The following is a description of a gene set: Mouse Gene Set: GOBP_REGULATION_OF_MITOTIC_CELL_CYCLE Any process that modulates the rate or extent of progress through the mitotic cell cycle. species: Mus musculus, and this is the list of marker genes: Eif4g1, Inhba, Pkd1, Poldip2, Ier3, Ttc28, Cdca8, Birc5, Cdc42, Pkn2, Taok2, Dbf4, Prpf4b, Cdc14a, Insr, Anapc15-ps, Fbxo5, Ube2u, Dusp3, Zfp36l1, Msh2, Cenpf, Actl6b, Kcna5, Ccdc8, Mbtps1, Timp2, Asah2, Clspn, Mir124a-3, Smpd3 (NCBI Gene Id 80691), Ythdc2, Sde2, Ccng1, Rcc2, Cdk6, Bex4, Pafah1b1 (platelet-activating factor acetylhydrolase, isoform 1b, subunit 1), Mbtps2, Pkmyt1, Mblac1, Ttll12, Myo16, Dcun1d3, Angel2, Etaa1, Ywhah, Nbn, Btg3, Cul4a, Rrm2b, Ccne2, Ddr2, Brca2, Tnf (tumor necrosis factor), Abl1 (NCBI Gene Id 98922), Mus81, Smarca2, Gjc2, L3mbtl1, Cdc20, Brca1, Crebbp, Xpc, Mtbp, Zwint, Cdc26 (cell division cycle 26), Bmp4, Ctdsp1, Atm, Cul4b, Pdpn, Cdkn2c (NCBI Gene Id 97133), Eme2, Mir124a-1, Rbl2, Mrnip, Kif14, Cyld, Actb, Smarcd3, Anapc4, Ppp2r3d, Gpnmb, Smoc2, Cdkn1c, Tcf3, Xrcc3 (NCBI Gene Id 74335), Slfn1, Ccnd2, Stox1, App, Rcc1, Tpra1, Rad21, Dapk3, Jade1, Fgf10, Rps27l, Mcidas, Fbxw5 (F-box and WD-40 domain protein 5), Wac, Brcc3, Rad9a, Cenpe, Mepce, Kank2, Plk3, Zwilch, Cdc6, Cdk5rap3, Kntc1, Ptch1, Dgkz, Phf10, Fzr1, Ins1, Fhl1, Smarcb1, Ttl, Ska1, Pcid2, Brsk1, Appl2, Ascl1, Tfdp1, Cdc73, Vps4a (vacuolar protein sorting 4A), Trp53, Nabp1, E2f7, Rad9b, Riok2, Mad1l1, Usp2, Tgfa, Epgn, Gen1, Egf, Atad5, Inip, Scrib, Plcb1, E2f1, Lsm10, Adamts1, Anapc5, Sik1 (salt inducible kinase 1), Hus1, Fbxo7, Cdc25c, Cdk11b, Hdac3, Atf2, Tipin, Blm, Pbrm1, Foxg1, Klf11, Khdc3, Tjp3, Nme6, Psme1, Ube2e2, Ticrr, Fam107a (NCBI Gene Id 268709), Zfp830, AY074887, Rgcc, Cdc23, Appl1, Cdca5, Brd4, Pebp1, Gigyf2, Atr, Nek7, Stk35, Aif1, Spc24, Pdik1l, Syf2, Eme1, Foxo4, Fbxo43 (F-box protein 43), Igf2, Cep192, Stat5a, Fgfr3, Trim39, Pdxp, Foxc1 (forkhead box C1), Uimc1, Rbm46, Senp2, Actl6a, Cul9 (cullin 9), Rbl1 (RB transcriptional corepressor like 1), Psmg2, Anapc15, Haspin, Igf1, Prkdc, Orc1, Nusap1, Plrg1, Brd7, Ndc80, Ptpn11, Ctdsp2, Smarcc2 (SWI/SNF related, matrix associated, actin dependent regulator of chromatin, subfamily c, member 2), Dmrt1, Tpr, Ins2, Chmp4c, Drd3, Creb3l1, Stil, Rad51b, Dtl (denticleless E3 ubiquitin protein ligase), Plk5, Mki67, Mnat1, Edn3 (endothelin 3), Camk2d, Zfyve19, Lmnb1, Cdk2ap2, Cul3, Bcl7c, Rprm, Topbp1, Btg4, Akt1, Smarcc1, Mad2l1bp, Bid, Cdc14b, Sin3a, Tunar, Hyal1, Brinp2, Nuf2, Cdk5rap2, Mir124a-2, Il1b, Aven, Rb1, Prap1, Cdkn1a, Sra1, Zmpste24, Il1a, Arhgap33os, Eif4e, Hnrnpu, Egfr, Arid1a, Npm2, Psme2, Asns, Prmt2, Arid2, Smarcd2, Nop53, Rrm2, Hnf4a, Tm4sf5, Cdc16, Spc25, Edn1 (NCBI Gene Id 13614), Rpa3, Gpr132 (G protein-coupled receptor 132), Tert, Mbd4, Sdcbp, Ttk, Cdkn1b, Cacnb4, Pim3, Esr1, Nae1, Iqgap1 (IQ motif containing GTPase activating protein 1), Tex14, Sh2b1, Rps6kb1, Pkd2, Bcl2, Klhl22, Zfp207, Zc3h12d, Lsm11, Trp73, Nherf1, Trim35, Cul7, Chek1, Bub3, Ccdc57, Ppp2ca, Cks1b, Ecd, Tgfb1, Larp7, Zw10 (zw10 kinetochore protein), Sass6, Apex1, Zfp655, Aurkb, Ccnd1, Smarca4, Fgfr1 (fibroblast growth factor receptor 1), Cdk10, Stat5b, Kmt2e, Dync1li1, Nabp2, Setmar, Tmod3, Pdgfb, Map3k20, Crlf3, Prkcq, Babam2, Anapc11, Lcmt1, Nek6, Psme3, Nkx3-1, D1Pas1, Plk1, Rdx, Ska3, Mir26a-1, Nle1, Fzd3, Ints3, Fgfr2, Phip, Fancd2, Dusp1, Foxn3 (forkhead box N3, NCBI Gene Id 71375), Dynlt3, Phb2, Smarce1, Pten, Ambra1, Cdkn2a, Tubg1, Pim1, Ctc1, Cdk2, E4f1, Shb, Tfap4, Gmnn, Cav2, Hsf1, Hacd1, Ints13, Anp32b, Cyp1a1, Cdkn2b, Zfp36l2, Nup62, Cts7, Usp47, Trip13, Aurka, Btc, Ptpn6, Ube2c, Dlg1, Rpl24, Anxa1, Ccnd3, Cpsf3, Nek9, Myc, D7Ertd443e, Dpf1, Rab11a, Meis2, Anapc7, Rad17, Brcc3dc, Heca (NCBI Gene Id 380629), Mir26b, Ereg, Mir26a-2, Rnaseh2b, Dpf3, Abraxas1 (NCBI Gene Id 71440), Stk33, Pbx1, Rint1, Ccl12, Pabir1, Ctdspl, Foxa1, Met, Ddb1 (damage specific DNA binding protein 1), Usp44, Ubd, Sphk1, Cenpj, Ccne1, Chfr, Pinx1, Nanog, Spdl1, Cks2, Ddx3x, Ankrd17, Men1, Id2, Prkca, Apc (NCBI Gene Id 11789), Eif4ebp1, Ovol1, Cdc25a, Ccnh, Ercc2, Bcl7b, Btn2a2, Rpa2, Rad51c, Bora, Ccnb1 (cyclin B1), Bard1, Lgmn, Ino80, Mdm2, Knl1, Wee1, Pim2, Nsmce2, Mta3, Pkia, Gbf1, Incenp, Ercc3, Bub1b, Cdk4, Hoxa13, Miip, Tal1, Acvr1, Gas1, Cdk3 (cyclin dependent kinase 3), Thap1, Klf4, Aatf, Pdgfrb, Cd28, Mre11a, Ywhae, Bmp7, Cdk1, Sirt1, Cdkn2d, Hmgb1, Usp22, Smarcd1, Trex1, Obsl1, Klhl18, Donson, Nek11, Cdc7, Dlgap5, Rrm1, Afap1l2, Rfwd3, Ezh2, Ppp1r10, Nfe2l1, Tom1l1, Taok3, Kcnh5, Chek2, Igf1r, Hus1b, Wnt10b, Bub1, Adam17, Vps4b, Rad50 (RAD50 double strand break repair protein), Neurog1, Dpf2, Cdca2, Dact1, Fbxo31, Cks1brt, Cdc25b, Mad2l1, Taok1, Rpl17, Hecw2, Rptor, Rps6, Bcl7a, Meioc, Cdk7, Ik, Lrp5, Trrap, Fgf8, Ptprv, Ctnnb1, Hspa2, Ccnb1-ps, Babam1, Pml, Ptpn3, Brinp1, Tom1l2, Rbbp8, Brinp3, Hes1